The following is a description of a gene set: Any process that modulates the frequency, rate or extent of pancreatic B cell development. Human Gene Set: GOBP_REGULATION_OF_TYPE_B_PANCREATIC_CELL_DEVELOPMENT species: Homo sapiens, and this is the list of marker genes: CLOCK, AKT1, BAD, NKX6-1 (NCBI Gene Id 4825), RFX3, GSK3A, RHEB, GSK3B, BMAL1